The following is a description of a gene set: Mouse Gene Set: GOCC_VESICLE_COAT species: Mus musculus A membrane coat found on a coated vesicle., and this is the list of marker genes: Ap1s3, Sec24b, Ap2a2, Snap91, Ap1m2, Pdcd6, Cope, Necap2, Ap2m1 (NCBI Gene Id 11773), Tbc1d5, Copg2, Copa, Tmed3, Clta, Trf, Pef1, Btbd8, Sar1a, Slc18a3, Epn2, Enthd1, Necap1, Ap1b1, Arcn1 (archain 1), Copz1, Sec23b, Ston1, Cltb, Epn3, Sec31b, Synrg, Ap1m1, Aftph, Eps15, Klhl12, Sar1b, Dipk2a, Copb2, Copg1, Ap1g1, Copz2, Sec23a, Ap1g2, Sec24d, Sgip1, Sec13, Cltc, Epn1, Scyl1, Ap2a1, Clint1, Sec31a, Ap1s1, Cideb, Sec24a, Clba1, Ap2b1, Copb1, Ap1s2, Sec24c, Ap2s1, Ston2